The following is a description of a gene set: In sickle cell disease, deoxygenation of intra-erythrocytic hemoglobin S leads to hemoglobin polymerization, erythrocyte rigidity, hemolysis, and microvascular occlusion. Ischemia-reperfusion injury, plasma hemoglobin-mediated nitric oxide consumption, and free radical generation activate systemic inflammatory responses. To characterize the role of circulating leukocytes in sickle cell pathogenesis we performed global transcriptional analysis of blood mononuclear cells from 27 patients in steady-state sickle cell disease (10 patients treated and 17 patients untreated with hydroxyurea) compared with 13 control subjects. We used gender-specific gene expression to validate human microarray experiments. Patients with sickle cell disease demonstrated differential gene expression of genes involved in heme metabolism, cell-cycle regulation, antioxidant and stress responses, inflammation, and angiogenesis. Inducible heme oxygenase-1 and downstream proteins biliverdin reductase and p21, a cyclin-dependent kinase, were up-regulated, potentially contributing to phenotypic heterogeneity and absence of atherosclerosis in patients with sickle cell disease despite endothelial dysfunction and vascular inflammation. Hydroxyurea therapy did not significantly affect leukocyte gene expression, suggesting that such therapy has limited direct anti-inflammatory activity beyond leukoreduction. Global transcriptional analysis of circulating leukocytes highlights the intense oxidant and inflammatory nature of steady-state sickle cell disease and provides insight into the broad compensatory responses to vascular injury. Genes up-regulated in peripheral blood mononuclear cells (PBMC) from sickle cell disease patients compared to those from healthy subjects. studied in species Homo sapiens from publication Jison ML, Munson PJ, Barb JJ, Suffredini AF, Talwar S, Logun C, Raghavachari N, Beigel JH, Shelhamer JH, Danner RL, Gladwin MT (PMID 15031206) Human Gene Set: JISON_SICKLE_CELL_DISEASE_UP, and this is the list of marker genes: FN1, LYL1 (LYL1 basic helix-loop-helix family member), VSIG4, UBE2L6, INTS4, MARCO, PSME2, ITGB5, CALR, RHEBP1, PSMA3, LHFPL2, NGFR, GUCY1B1, F13A1, NNAT, KYNU, BLVRB (NCBI Gene Id 645), P4HB, TP53I11, LILRA2, JAK2, VAMP5, TALDO1, LY6E, HMOX1 (NCBI Gene Id 3162), MPP1, BST2, TIMM17A, HBB, IFI30, ATF3, SLC36A1, RSAD2, TYMP, TCN2, H2AC18, IFI44, IQCE, GM2A, P2RX4, H2BC12, IL15, LAMP2, ANXA2, C6orf120, ZMPSTE24, VAMP8, PSMB2, TXNRD1, CTSG, ABLIM3, IGF2BP3, PSMB9 (proteasome 20S subunit beta 9), GTF2B, CCR2, BLOC1S1, ELANE, NDUFB7, AZU1, UBE2L3, MICB (NCBI Gene Id 91956), NAB1, RHOA, ATP6V1D, STAT1, NUCB1, RENBP, TXN, RAB13, SLC22A4, RNASE2, ANXA3, SLC2A3, CDS2 (CDP-diacylglycerol synthase 2), TPM1, PPP2CB, SPTLC2, CALCOCO2, AXL, RSU1, HLA-A, MITF, CDKN1A, EIF4A3, EPHB2, NDUFAF3, RHOBTB1, CHP2, PTCRA, PSMB8, TRIP6, CD151, FCGR1A, SNN, PCK2, NREP, MX1, GADD45B, CTSL, SQLE, DYNLT1, RNF24, CRADD, CTSA, CD9, ATP6V0A1, TCTA, ITGB3, TIMP1, CLIC1, STX7 (NCBI Gene Id 8417), NFE2, LEPROT, GNPDA1, DOK1, MKNK1 (NCBI Gene Id 8569), RIT1, H1-0, SMOX, YWHAH, CCRL2, BLVRA (biliverdin reductase A), CXCL10, GNG11, UBE3C, PTPRO, CUL1, IFIT1, EMP3, BNIP3L, IFIT2, GAS2L1, OASL, DESI1, TMED1, TAP1, ST3GAL5, ATOX1, PRDX1, TFEC, MYL9, TUBB2A, IFI35, COX17, MPO, DDIT3, ITGA2B, NDUFS2, GBP2, CPLX2, CLIC4 (chloride intracellular channel 4), VRK2, IFIT3, ATP1B1, CEBPE, WSB2, PLEK, NEK4, GBP1, CASP7, HBA1, PTK2, XK, NFKBIE, LIPA (NCBI Gene Id 3988), SELP, ADM, HTATIP2, CLIC2, GSTO1, GADD45A, ZNF267, RRP7A, AKR1A1, TDRD7, GNG5, RGL1, PLIN3, PRDX4, SERPING1, NOTCH3, LMNB1